The following is a description of a gene set: Genes down-regulated in comparsion of ActCD8 versus ActCD4 (see Fig. 1 in the paper for details). from publication Hill JA, Feuerer M, Tash K, Haxhinasto S, Perez J, Melamed R, Mathis D, Benoist C (PMID 18024188) species: Homo sapiens The transcription factor Foxp3 is usually considered the master regulator for the CD4+CD25+ Human Gene Set: GSE7460_CD8_TCELL_VS_CD4_TCELL_ACT_DN, and this is the list of marker genes: OSBPL2, GPR155, GYPC, ANKRD27, H2BC5, MYO18A, RB1, PCCB, MTMR3, ASS1, ZNF623, DIP2C, PPP4R1, NME6, ST6GAL1, CD2AP, ZRANB1, MYO10, ADPGK, HYPK, PLEKHA1, MLLT3, ANP32A, PARD6G, SBF2, SLPI, GABRR2, P2RX7, FNBP1L, CAPNS1, EGLN2, GNB4, NUSAP1, TMEM121, SPTSSA, AHCTF1, AGRP, C2CD5, EPHX4, PDLIM4, CENPA, GPSM2, AIPL1, ARHGAP29, DUSP7, RPA1, KIFBP, ARHGAP5, UCP2, POLL, MAF, WFS1, AMPD3, USP27X, LRRC8D, PLXND1, GGACT, PTPRA, GNG12, ZNF236, REC8, CGGBP1, UBE2E2, DAP3, CD4, SDR16C5, SAP18, CENPM, TGM4, NSUN4, CNST, SH3BGRL2, GOLPH3L (golgi phosphoprotein 3 like), HNRNPLL, DRC1, APP, RCN1, MDFIC, ITGB3, NLRP10, ST6GALNAC2, TMEM267, RAB1A, CENPL, MSI2, WDR83OS, CENPE, C1orf198, NEB, COPG1, GAS2L3 (NCBI Gene Id 283431), CTBP1 (NCBI Gene Id 1487), RPUSD4, C8orf82, CDON, NDUFA8, FKBP1A, ATP11C, AMBN, NFIX, ARHGEF11, VCF1, SPEF1, PRNP, FRY, RGCC, BCAT2, AP2S1, KCTD13, MIA2, SPRY1, CSGALNACT1, BTLA, UBE2A (ubiquitin conjugating enzyme E2 A), SH3GLB2, TMEM168, TMEM64, HMGB1, IFT46, NDUFB3, HSBP1, ETS2, SHE, FOXK1, FRMD6, IFITM3, ATP2B1, CEP89, HSD11B1, IBTK, FAM177A1, RASGRP1, TCF20, IGFBP4, TMEM154, CD81, NREP, COX6C, ERI2, GCC2, SLC25A22, AKT2, IL1RL2, AVEN, TP63, MBOAT1, STK24, SEPTIN7, RCBTB1, TIAM1, COA7, AIRE, AHCYL2, LARS2, TDRKH, MPZL3, PRICKLE1, SLC25A24, TRAT1, PLCL2, BCL9 (NCBI Gene Id 607), VARS2, CREG1, CDKN1C, XXYLT1, S100A13, ANKRD50, MDH2, TMCC3, PKP4, ANXA5, GM2A, ZCCHC24, FADD, GPR83, EXO5, CLN6, VWA1, METTL14, ZFAND5, TNKS2, THBD, TOX, HSD17B10, IZUMO1R, TMEM176B, RAMP1, SUMF2, USP6NL, PPP2CA, DNAJB14, MYO6, LYPLAL1, SNN, UBE4B, XIRP1, KIF3A (kinesin family member 3A), FAM219B, ECM1, CDR2